The following is a description of a gene set: Mouse Gene Set: GOMF_BETA_2_ADRENERGIC_RECEPTOR_BINDING species: Mus musculus Binding to a beta-2 adrenergic receptor., and this is the list of marker genes: Bdkrb2, Pde4d, Prkar2a, Dlg4, Ppp2ca, Akap5, Nherf1, Gria1, Gnas, Nedd4